The following is a description of a gene set: Mouse Gene Set: GOBP_ENERGY_HOMEOSTASIS species: Mus musculus Any process involved in the balance between food intake (energy input) and energy expenditure., and this is the list of marker genes: Mir369, Trpv4, Ucp1, Appl2, Rrp8, Mir487b, Fmo1, Mir376a, Sctr, Mir379, Mir299a, Oma1, Slc35d3, Mir381, Prkaa1, Sucnr1, C1qtnf4, Mir654, Acacb, Col6a1, Mir758, Lepr, Bmp8b, Mir376b, Suv39h1, Alk, Guca2b, Mir543 (microRNA 543), Wnk4 (WNK lysine deficient protein kinase 4), Mir377, Prkaa2, Nmur2, Lipa, Nmu, Stat3, Mc4r, Mir485, Atf2, Mir667, Tmem18, Bmal1, Crtc1, Acvr1c (activin A receptor, type IC), Prlh, Mir323, Igf2bp2, Mex3c, Clic5, Adrb1, Bola3, Cckar, Cebpa, Prcp, Cntnap2, Mfsd2a, Mir382, Irx3, Pik3ca, Mir679, Mir539, Trpv1, Mir299b, Nr1d2, Acbd7, Sgip1, Metrnl, Sirt1, Crtc3, Ppargc1b, Mir134, Nr4a3, Pcsk1n, Pprc1, Mrap2, Eif4g1, Gfral, Slc25a25, Gpr82, Tsku, Dll1, Lep, Pparg (NCBI Gene Id 19016), C1qtnf9, Enpp1, Sct, Fmo4, Mir410, Apoe, Mir1193, Mir496a, Rasal2, Ampd3 (adenosine monophosphate deaminase 3), Gdf15, Ampd2, Mir668, Vgf, Adrb3, Pnpla3, Rmi1, Mapk14, Mir495, Sqstm1, Stk39, Ceacam2, Ccdc198, Ppard, Mir1197, Mir300, Mir496b, Pask, Mir409, Gdf3, Mir544, Mir453, Mir494, Ppargc1a, Gpr39, Flcn, Mir154, Mir412, Mir541, Tbl1xr1, Cd36, Ubb, Mir329, Adrb2, Sorl1, Twist1, Mapk8, Cntn2, Mlxipl, Mir376c, Cfh, Edn2, Mir411, Fmo2, Mir380, Mir666, Pm20d1, Fcor